Given this list of marker genes BCAT2, MCCC1, AGXT, HMGCL, MCCC2, GPT, AUH, AGXT2, IVD, HMGCLL1, DAO (NCBI Gene Id 1610), BCKDK, GPT2, here is a description of the gene set: Human Gene Set: GOBP_PYRUVATE_FAMILY_AMINO_ACID_METABOLIC_PROCESS species: Homo sapiens The chemical reactions and pathways involving any amino acid that requires pyruvate for its synthesis, e.g. alanine.